The following is a description of a gene set: studied in species Homo sapiens Human Gene Set: GOBP_POSITIVE_REGULATION_OF_TYPE_B_PANCREATIC_CELL_APOPTOTIC_PROCESS Any process that activates or increases the frequency, rate or extent of type B pancreatic cell apoptotic process., and this is the list of marker genes: CAPN10 (NCBI Gene Id 4812), HDAC3, EIF2S1, IL6, ISL1